The following is a description of a gene set: electronically inferred by orthology from the curated human pathway studied in species Mus musculus Reactome Pathway: Platelet sensitization by LDL This event has been computationally inferred from an event that has been demonstrated in another species.<p>The inference is based on the homology mapping from PANTHER. Briefly, reactions for which all involved PhysicalEntities (in input, output and catalyst) have a mapped orthologue/paralogue (for complexes at least 75% of components must have a mapping) are inferred to the other species. part of: Platelet homeostasis, and this is the list of marker genes: Mapk14, Ptpn6, Fgr, Lrp8, Ppp2r5a, Apob, Ppp2r5d, Ppp2r1b, Ppp2r5b